Given this list of marker genes INPP5F, NFKB1, PLCH1, ITGB2, RNF141, ERI1, PLXNB2, PKIG, PAFAH1B2 (platelet activating factor acetylhydrolase 1b catalytic subunit 2), CTCF, ACRBP, KIF1C, ID2, C9orf72, MVB12B, FRMD4B, EML5, CAPN2, FGF13, CKB, TOP2B (NCBI Gene Id 7155), RAD51C, KCNMB4 (potassium calcium-activated channel subfamily M regulatory beta subunit 4), AP1S3, TMEM109, NOL11, LPXN, SLC44A1, ARID1A, HNRNPH2, SMCO3, NEK7, MATN2, UBE2Z, KRT28, EGFL7 (NCBI Gene Id 51162), UHMK1, GUCY1A2, DCAF12, MTPN, RBM47, EPB41L2, ZDHHC13, TMED10, TRIM35, SEMA6D, BANK1, UBE2E1, DNAJC24, MEF2C, ENC1, RBMX, B3GNT5, ARF1, NRP1 (NCBI Gene Id 8829), RTN4IP1, CPNE1, NIBAN2, FAM234A, TBC1D10B, APCDD1, SEMA3D, ESCO2, SSB, CCDC103, MINDY3, ASXL2, CDC20, CD38, KLHL30, AMELX, RASAL1, CD180, KIFC1, FUT4, DPP4, RAB40C, STX12, SUB1, KRT81, CRNKL1, ZDHHC19, CHML, PLEKHH1, GNG2, SATB1, E2F2, ARHGAP30, NOSTRIN, MPEG1, MN1, ELK1, HIVEP2 (NCBI Gene Id 3097), KIF3C, MLLT6, SH3BP5, TMED8, AMBRA1, TXNDC16, DCHS1, FURIN, IL13RA1, POLA1, HRAS, EIF4G2, LIPA, TMEM229B, MBD2, GTF2A1, RNF157, NUCKS1, GPR183, MFHAS1, CEP170B, DGLUCY, DDX59, JUNB, ACVR1C, CTBS, SSH2 (slingshot protein phosphatase 2), TP53TG5, LAPTM5, STK10, ARID3B, VAV2, KLF4, ATP13A2, E2F8, SECISBP2L, ATAD2B, GLIS2, TMEM79, ARL6IP6, CAMKK1, CACNA2D4, PAFAH1B1, HESX1, RCBTB1, HSPA9, CPEB3, OPN3, TRIM59, BMF, PLCD3, MSRB3, MYEF2, ITGA1, CGN, CRYL1, MYADM, AP1S2, CAMSAP2, FGF1, CLCN5, SKA3, RBPJ, MELK, RAPH1, ZNF799, KIF2C, PURB, METTL4, C6orf58, NAPB, TLK2, KNL1, AKT3, MEX3D, UCHL1, PIK3R3, DDI2, PRSS23, YOD1, SMAD6, MTUS2, ANKLE2, NABP1, PRSS45P, CMTM2, HOXA3, ACOT11, EVL, PDE7A, ITGB5, UBE2D2, L1CAM, SLC30A4, PDCD6IP, PIK3R5, FAM135A, RPS6KA5, SLAMF6, FAM76A, CAAP1, AMZ1, GABRR2 (gamma-aminobutyric acid type A receptor subunit rho2), CLUAP1, ITPA, CHST7, CASP1, here is a description of the gene set: Human Gene Set: GSE25088_IL4_VS_IL4_AND_ROSIGLITAZONE_STIM_MACROPHAGE_DAY10_UP species: Homo sapiens C57Bl/6 wild-type and STAT6 KO mice were used to study PPARg and IL-4 signaling. Bone marrow of 3 mice per group was isolated and differentiated to macrophages with M-CSF (20 ng/ml). 20 ng/ml IL-4 was used to induce alternative macrophage activation and 1 uM Rosiglitazone (RSG) was used to activate PPARg. From each mouse 4 samples were generated: 1. M-CSF, 2. M-CSF+RSG, 3. IL-4 and 4. IL-4+RSG. All compounds were added throughout the whole differentiation process, and frech media was added every other day. Control cells were treated with vehicle (DMSO:ethanol). After 10 days, RNA was isolated and gene expression profiles were analyzed using Mouse Genome 430 2.0 microarrays from Affymetrix. Genes up-regulated in wildtype bone marrow-derived macrophages treated with IL4: control versus rosiglitazone. from publication Szanto A, Balint BL, Nagy ZS, Barta E, Dezso B, Pap A, Szeles L, Poliska S, Oros M, Evans RM, Barak Y, Schwabe J, Nagy L (PMID 21093321)